The following is a description of a gene set: species: Mus musculus Mouse Gene Set: GOMF_RNA_POLYMERASE_II_SPECIFIC_DNA_BINDING_TRANSCRIPTION_FACTOR_BINDING Binding to a sequence-specific DNA binding RNA polymerase II transcription factor, any of the factors that interact selectively and non-covalently with a specific DNA sequence in order to modulate transcription., and this is the list of marker genes: Hdac1, Gsc, Cpne1, Srarp, Cdk5rap3, Trp53, Sin3a, Cry2, Mkks, Mef2a, Keap1, Padi2, Spi1, Spop, Fus, Dnaja1, Gbx2, Taf1 (NCBI Gene Id 270627), Nfkbid, Trp53bp1, Hspa1b, Ddx5, Ptprt, Neurod1, Ptpn2, Nr1i2, Gtf2i, Med1, Foxh1, Prkdc, Sdr16c5, Csnk2b, Hdac5, Tbx5, Sra1, Tbp, Mixl1, Taf10, Hspb1, Ddrgk1, Hnf4a, Prdm13, Egr2, Ppargc1b, Pdcd11, Rarg, Taf4b, Akap8, Nr4a1, Med30, Elk1, Dcaf13, Tacc2, Lhx3, Dnmt3a (NCBI Gene Id 97846), Nr1h2 (nuclear receptor subfamily 1, group H, member 2), Foxc1, Mad2l2, Actb, Med24, Dot1l, Cd34, Ncor2, Pitx1, Parp1, Psmc3ip, Bbs2, Dll1, Daxx, Bbs10, Sp3, Nr0b1, Tcf23, Tfdp1, Pkn1, Tcerg1, Trip12, Tmf1, Setd3, Pou5f1, Nkx3-1, Rbbp8, Commd7, Zfp366, Gabarapl1 (NCBI Gene Id 93738), Dcaf1, Epas1, Uimc1, Arap1, Ncoa3, Uba3, Crebbp, Dnmt1, Mef2d, Uhrf2, Tcf7l2, Wwp2, Kdm1a, Dhx9, Rarb, Med4, Park7, Gata1, Zbtb8a, Lrp2, Lef1, Hdac9, Foxp1, Sox2, Ywhah, Cdkn2a, Tbx6, Zfpm2, Isl1, Fkbp4, Nr4a2, Kat8, Bcas3, Taf11, Bmal1, Foxl2, Ets1, Smarca4, Tcf3 (transcription factor 3), Mta2, Gata3, Pitx2, Smad3, Trp73, Kdm5d, Pik3r1, Xpc, Med16, Asah1, Tgfb1i1, Tacc1, Stk4, Ttc8, Esr1, Foxp3, Pou4f1, Parp9, Trib2, Mlxipl, Nkx2-5, Bex1, Ctdp1, Calr, Ncoa2, Mms19, Rnf25, Hand2, Myocd, Smarca1, Ncoa6, Lmo2, Commd8 (NCBI Gene Id 97223), Smarce1, Cebpa, Bbs7, Brd8, Hsd17b10, T, Arrb1, Prrx1, Fbp1 (fructose bisphosphatase 1), Lrif1 (ligand dependent nuclear receptor interacting factor 1), Notch2, Hira, Id4, Per2, Ankrd2, Taf7, Gtf2b, Ppid, Zfpm1, Mecr, Strn, Kdm5c, Nrbf2, Src, Atf2, Ankrd42, Prkcb, Nfe2l2, Nfkbia, Med17, Ifi27, Hes6, Pparg, Csrp3, Cry1, Smarcb1, Gsk3b (NCBI Gene Id 98033), Jup, C1d, Dact1, Rela, Fos, Tob2, Slc30a9, Lpin1, Ctnnb1, Cebpb, Rxra, Ahr, Ctbp1, Dtx3l, Asxl1, Wipi1 (WD repeat domain, phosphoinositide interacting 1), Pagr1a, Ncor1, Sp100, Actn4, Mapk14, Ets2, Pcna, Foxp2, Bud31, Tal1, Rbpj, Nrip1, Ppard, Smad2, Ddx54, Ncoa1, Bbs1, Kdm4c, Hipk2, Rest, Pias2, Aip, Nif3l1, Mdfic, Pou1f1, Lcor, Commd6, Klf4, Ccdc62, Zbtb7a, Hr, Psma6 (NCBI Gene Id 26443), Nr1h3, Bcl10, Ppargc1a, Mkx, Med25, Rxrb, Myod1, Setd6, Arid1a, Hmgb1, Nr0b2, Fiz1, Taf4, Hif1an, Hey2, Hdac4, Ifrd1, Ep300, Snw1, Prpf6, Npm1, Sting1, Smarcd3, Ipo13, Crx, Hes1, Trerf1, Stat3, Ddit3, Trib1, Tada3, Sirt1, Eomes, Srf, Ubxn7, E4f1, Gfi1b, Rb1, Gtf2h1, Arnt2, Hsf1, Gata4, Hand1, Spen, Nkx2-1, Setd1a, Hcls1, Id2, Rad23b, Rbx1-ps, Exosc9, Ar, Taf6, Hspa1a, Med12, Mef2c, Tox2, Anxa4 (annexin A4), Stat5b, Hdac3, Hspa4, Atf4, Cnot1, Nhlh2, Trip4, Rnf4, Cited2, Ppara, Bhlhe41, Add1, Tbx20, Bbs5, H2bc24, Rnf6, Trim24, Dnaja3, Trim68, Jun, Ldb1 (NCBI Gene Id 16825), Bhlhe40, Crkl, Thrap3, Esrrb, Fam220a, Mtdh, Pramel13, Mlx (NCBI Gene Id 56875), Hmga1b, Psmd10, Gata6, Prmt2, Nr4a3, Tead3, Sp1, Nsd1, Sall1 (NCBI Gene Id 58198), Jund, Hmga1, Mta1, H2bc9, Faf1, Med13, Chd4, Sumo2, Kdm3a, Prox1, Ncoa7 (nuclear receptor coactivator 7), Stat1, Foxa1, Bex2, Hdac2, Gtf2a1, Sox17, Arid5a, Dmap1, Grm1, Nr1h4 (nuclear receptor subfamily 1, group H, member 4), Tbx18, Hmga2, Wbp2, Tbx3, Dusp26 (NCBI Gene Id 66959), Creb1, Bbs4, Dnaaf4, Rnf14, Brms1, Ankrd1, Hey1, Gata2 (GATA binding protein 2), Smad4, Tcf21, Gtf2a2, Lats1, Trp53bp2, Vdr, Ctbp2, Arnt (aryl hydrocarbon receptor nuclear translocator), Nfatc1, Apex1, Rbx1, Flt3, H2bc23, Hif1a, Nup62